Given this list of marker genes Wdhd1, H2ac22, Brca1, H2al1j, Morc2b, H2ac13, Spty2d1, H2ab2, Mbd2, Pcid2, Sirt7, Hmga2, H2al1f, Trim37, Zfp57, Prdm14, Ctcf, Mecp2, Znfx1, Tfap2c, Cbx3, Sdr16c5, H2al1m, Hdac4, H2az2, H2ac11, Jpx, Bap1, Piwil1, Pole3, H2al2a, Macroh2a1, Kmt2a, Baz2a, Mettl3, Suz12, Ifi206, Sirt1, Ifi213, H2az1, H2al3, Bmi1, Ifi214, Kmt2d, Ehmt2, Btbd18, Rb1, Kmt2b, Mov10l1, Cbx1, Ezh2, H2ac4, Pcgf3 (polycomb group ring finger 3), H2ac24, Lhx2 (LIM homeobox protein 2), Mphosph8, Phf8, Tut7, Morc1, Bend3, Zfp869, Kdm5a, Ing2, Lbr, H2al1o (NCBI Gene Id 333452, H2A histone family member L1O), Atf7ip, Rsl1, Mtf2, Smarca5, Hdac1, Ctr9, Ezh1, Crebzf, Prmt5, Ubr2, Uty, H2ac23, Tdrd12 (tudor domain containing 12), Spin1, Rlim, Ifi203-ps, Dnmt1, Hdac2, Rif1 (NCBI Gene Id 99400), Trim28, Zfy2, Hnrnpu, Piwil2, H2al1k, Tsix, Atrx, Samd7, Kat8, Mbd3, Tdrd9, Usp7, Smarca1, Smarca2 (NCBI Gene Id 67155), Chek1, Trip12, H2ab3, Dnmt3a, Ftx, H2ac6, H2ax, Morc2a, Cdk2, Mbd1, Upf1, Tnp1, Tex19.1, H2al1e, Mov10, Dubr, Bahd1, H2aj, Sirt2, Rbm15, Xist (inactive X specific transcripts), Ddx4, Dnmt3b, Ppm1d, Spen, Dot1l, Dicer1, Bmyc, Hotair (NCBI Gene Id 100503872), Ifi207, Cbx8 (NCBI Gene Id 30951), Uhrf2, Scmh1, Dyrk1a, Rrp8, Wt1, Uhrf1, Mettl4, Fkbp6, Baz1a, Hdac6, Suv39h2, Airn (NCBI Gene Id 72704), Smarca4, H2ac21, Smarcad1, H2ac8, H2ac12, Mndal, Ifi208, Hdac8, Resf1, H2ac7, Piwil4, Arb2a, H2al2b, H2ac25, Apobec3, Tex15, Dnmt3l, Ncor2, Lmna, Eif1, Mcrip1, Tdrd5, Mbd3l1, Cdyl, Gm38999, H1f9, Phf2, Phf19, H1f0, Zfp445, Ifi209, H2ac20, Cbx5, Pphln1, Eed, H2ac10, Spocd1, Sin3a, Lmnb1, Mta1, Tex19.2, Myc, Phf1, Setdb1, Mael, Mis18a, Mbd3l2, Hat1, Tasor, Tut4, Tpr, Nrde2, Lrif1, Cenpv, Epc1, H2ap, Ythdc1, Tasor2, Bcl6, Kcnq1ot1 (KCNQ1 overlapping transcript 1), Upf3a, H2al1b (H2A histone family member L1B), Hdac9, Hdac3, Exosc10 (exosome component 10), Suv39h1, Rlf, Jarid2, H2al1n, Smchd1, Lmnb2, H2ac15, H2ac19, Hells, Trim27, Tdrd1, L3mbtl1, Asz1, H2ac1, Ubr5, Sirt6, Rbm15b (NCBI Gene Id 76348), Ehmt1, Hnrnpk, Macroh2a2, Upf3b, H3f3b, Pcgf5, Smyd5, Ifi203, N6amt1, H3f3a, H2ab1, here is a description of the gene set: An epigenetic process that silences gene expression at specific genomic regions through chromatin remodeling either by modifying higher order chromatin fiber structure, nucleosomal histones, or the cytosine DNA methylation. Mouse Gene Set: GOBP_NEGATIVE_REGULATION_OF_GENE_EXPRESSION_EPIGENETIC studied in species Mus musculus